Given this list of marker genes Mdm2, Usp5, Gabarap, Fbxo22, Cav1, Fzr1, Sumo3, Pbk, Rpl5, Plk1, Qrich2, Agbl4, Bag5, Apoe, Tmem67, Paqr3, Tlk2, Smurf1, Rpl23, Psen1, Pabir1, Rnft1, Mapk8, E330034G19Rik, Nudt15, Psme3ip1, Wnt1, Dvl1, Ophn1, Hspa1a, Clu, Zyg11b, Prkn, Traf7, Eif2a, Map1a, Fbxw7, Gpx1, Hfe, Xbp1, Ufl1, Ube2v2, Pten, Hsp90ab1, Shh, Tgfb1i1, Det1, Pithd1, Ern1, Dab2ip, Rybp (RING1 and YY1 binding protein), Ubqln2, Psmd14, Cdc20, Usp19, Glmn, Rps7, Commd1, Uchl5, Nfe2l1, Ubb, Xpo1 (NCBI Gene Id 103573), Nop53, Ufsp2, Anks1, Gna12, Trf, Fmr1, Zfand2a, Bcap31, Dab2, Alad, Usp26, Osbpl7, Zer1, Trem2, Styx, Kcne2, Cdc20b, Bag2, Styx-ps, Gsk3b, Ddrgk1, N4bp1, Sirt2, Gba1, Lrrk2, Ccdc22, Usp13, Klhl40, Aqp11 (NCBI Gene Id 66333), Mtm1, Il33, Lamp3, F8a, Csnk2b, Svip, Smarcc1, Pias1, Ttc36, Wac, Hspa1b, Trim39, Csnk1e, Vcp, Ctsc, Pdcl3, Sgta, Rnf180 (ring finger protein 180), Disc1, Oaz1, Gclc, Ubqln4, Plk3, Atxn3, Senp1, Araf, Nub1, Fhit, Sh3rf2, Dnaaf4, Rybp-ps, Chfr, Ube3a, Pkd1, Mapk9, Rbx1-ps, Rpl11, Prickle1, Psmf1, Rnf185, Zfp418, Stub1, Cop1, Prkcg, Aurka, Ptk2, Axin2, Prmt6, Akt1, Socs4, Herpud1, Nupr1, Csnk1d, Taf9, Usp14, Cbfa2t3, Psme1 (NCBI Gene Id 19186), Park7, Ccar2, Csnk2a2, Usp25, Atg7, Rad23a, Sirt1, Ubxn1, Tmtc3, Dnajb2 (DnaJ heat shock protein family (Hsp40) member B2), Sco1, Rbx1, Atp5if1, Gabarapl2, Hipk2, Bag6, Clec16a, Rnf40, Rchy1, Ogt, Sumo1, Psme2, Csnk1a1, Phf20l1, Lats1, Wfs1, Tmem259, Usp38, Rhbdf1, Trib1, Fbxw8, Gsk3a, Ptk2b, Caml, Desi1, Ubqln1, Mtor, Tmem168, Rgn, Trib2, L3mbtl3, Nkd2 (naked cuticle 2), Trib3, Cdk5rap3, Sh3rf1, Efna1, Dda1, Gipc1, Hamp, Sufu, Eif3h, Socs5, Trim67, Bbs7, Usp9x, Sumo2 (NCBI Gene Id 235709), Wnt10b, Usp7, Foxf2, Ubxn2a, Plk2, Agtpbp1, Ube2k, Dlgap1, Epha4 (Eph receptor A4), Prkaca, Hspbp1, Psmd10, Rnft2, Laptm5, Marchf7, Sirt6, Cdkn2a, Rack1, Epm2a, Tmx1 (thioredoxin-related transmembrane protein 1), Axin1, Pabpn1l, Egf, Psen2, Btrc, Eif2ak3, Rad23b, Rnf139 (NCBI Gene Id 75841), Psme3, Tmf1, Sh3rf3, Ecscr, Pml, here is a description of the gene set: species: Mus musculus Mouse Gene Set: GOBP_REGULATION_OF_PROTEOLYSIS_INVOLVED_IN_PROTEIN_CATABOLIC_PROCESS Any process that modulates the frequency, rate or extent of proteolysis involved in cellular catabolic process.